The following is a description of a gene set: Identifying variations in DNA that increase susceptibility to disease is one of the primary aims of genetic studies using a forward genetics approach. However, identification of disease-susceptibility genes by means of such studies provides limited functional information on how genes lead to disease. In fact, in most cases there is an absence of functional information altogether, preventing a definitive identification of the susceptibility gene or genes. Here we develop an alternative to the classic forward genetics approach for dissecting complex disease traits where, instead of identifying susceptibility genes directly affected by variations in DNA, we identify gene networks that are perturbed by susceptibility loci and that in turn lead to disease. Application of this method to liver and adipose gene expression data generated from a segregating mouse population results in the identification of a macrophage-enriched network supported as having a causal relationship with disease traits associated with metabolic syndrome. Three genes in this network, lipoprotein lipase (Lpl), lactamase beta (Lactb) and protein phosphatase 1-like (Ppm1l), are validated as previously unknown obesity genes, strengthening the association between this network and metabolic disease traits. Our analysis provides direct experimental support that complex traits such as obesity are emergent properties of molecular networks that are modulated by complex genetic loci and environmental factors. Human Gene Set: CHEN_LIVER_METABOLISM_QTL_CIS studied in species Mus musculus Cis-regulated expression quantitative loci (cis-eQTL) in the liver that contribute to metabolic quantitative traits (weight, fat mass, and plasma glucose and cholesterol levels). from publication Chen Y, Zhu J, Lum PY, Yang X, Pinto S, MacNeil DJ, Zhang C, Lamb J, Edwards S, Sieberts SK, Leonardson A, Castellini LW, Wang S, Champy MF, Zhang B, Emilsson V, Doss S, Ghazalpour A, Horvath S, Drake TA, Lusis AJ, Schadt EE (PMID 18344982), and this is the list of marker genes: RPS6KC1, DBI, RGS5, PLXNA2, DUSP12, FCER1G, C1orf53, APCS, PCP4L1, DCAF8, RAB3GAP1, FMN2, CRYZL2P, GLRX2, PYHIN1, KMO, SLC35F5, COPA, PTPRVP, TATDN3, AGXT, ZRANB3, FAM20B, CFHR1, CD244, LAD1, LRRFIP1, SLC30A1, SMYD2, MLPH, TSEN15 (tRNA splicing endonuclease subunit 15), CDH19, DUSP23, SCLY (selenocysteine lyase), PIGM, FMO4, SPTA1, NIT1, UCHL5, TMEM183A, CENPL, PIGN, NENF, TOR1AIP1, VPS4B (vacuolar protein sorting 4 homolog B), KLHDC9, ITLN1, GREM2, MRPS14, DDR2, CEP170, DARS2, NAV1, PRG4, CD48, RGS18, HES6, CAPN10, TMEM37, ADAMTS4, ODR4, CFAP126, ACTR3, MAB21L4, C2orf76, CYB5R1, RAB17, F11R, BPNT1, TLR5, INSIG2, C1orf115, IARS2, PPOX (protoporphyrinogen oxidase), RGS7, B4GALT3, APOA2, GAS5, SLAMF6, PPFIA4, RABGAP1L, IVNS1ABP, SNED1, UAP1, MTARC1, IGSF8, FMO1, TSTD1, NME7, SDHC, FCGR2B, USF1, MARCO, SOAT1, HSD17B7